Given this list of marker genes CCL2, ACKR1, TNFAIP6, L1CAM, KRT19, KRT15, MAP2K1, PGF, PML, CRABP2, PLAU, here is a description of the gene set: Arsenic compounds are widely distributed and arsenic ingestion is associated with many human diseases, including blackfoot disease, atherosclerosis, and cancers. However, the underlying mechanism of arsenic toxicity is not understood. In human fibroblast cells (HFW), arsenite is known to induce oxidative damage, chromosome aberrations, cell cycle arrest, and aneuploidy, and the manifestation of these cellular responses is dependent on changes in gene expression which can be analyzed using the cDNA microarray technique. In this study, cDNA microarray membranes with 568 human genes were used to examine mRNA profile changes in HFW cells treated for 0 to 24 h with 5 microM sodium arsenite. On the basis of the mean value for three independent experiments, 133 target genes were selected for a 2 x 3 self-organizing map cluster analysis; 94 were found to be induced by arsenite treatment, whereas 39 were repressed. These genes were categorized as signal transduction, transcriptional regulation, cell cycle control, stress responses, proteolytic enzymes, and miscellaneous. Significant changes in the signaling-related and transcriptional regulation genes indicated that arsenite induces complex toxicopathological injury. from publication Yih LH, Peck K, Lee TC (PMID 12016162) Genes in cluster 5: slowly down-regulated in HFW cells (fibroblast) by sodium arsenite. studied in species Homo sapiens Human Gene Set: YIH_RESPONSE_TO_ARSENITE_C5